The following is a description of a gene set: studied in species Mus musculus The chemical reactions and pathways resulting in the breakdown of a protein or peptide by hydrolysis of its peptide bonds, initiated by the covalent attachment of ubiquitin, with ubiquitin-protein ligation catalyzed by an SCF (Skp1/Cul1/F-box protein) complex, and mediated by the proteasome. Mouse Gene Set: GOBP_SCF_DEPENDENT_PROTEASOMAL_UBIQUITIN_DEPENDENT_PROTEIN_CATABOLIC_PROCESS, and this is the list of marker genes: Rbx1-ps, Fbxo38 (NCBI Gene Id 107035), Fbxo48, Fbxl16, Fbxl5, Fbxl9, Fbxo2, Fbxl3, Fbxo39, Rbx1, Styx-ps, Fbxo4, Btrc, Fbxo3, Fbxo9 (f-box protein 9), Skp1, Cul5, Fbxo17, Fbxl17, Amn1, Fbxo31, Wwtr1, Cul1, Fbxo27, Fbxl7, Fbxl20, Kif14, Nccrp1, Fbxl2, Fbxl6, Fbxl15, Cul2, Dmac2, Fbxw7, Fbxl18, Fbxw5, Skp2, Pabpn1l, Fbxw11, Fbxl4, Ccnf (cyclin F), Fbxw4, Fbxo44, Fbxo6, Fbxl14, Styx, Fbxl13, Fbxl22